The following is a description of a gene set: from publication Weber M, Hellmann I, Stadler MB, Ramos L, Pääbo S, Rebhan M, Schübeler D (PMID 17334365) Human Gene Set: WEBER_METHYLATED_ICP_IN_SPERM_UP Methylated germline-specific genes with intermediate-CpG-density promoters (ICP) in sperm. studied in species Homo sapiens To gain insight into the function of DNA methylation at cis-regulatory regions and its impact on gene expression, we measured methylation, RNA polymerase occupancy and histone modifications at 16,000 promoters in primary human somatic and germline cells. We find CpG-poor promoters hypermethylated in somatic cells, which does not preclude their activity. This methylation is present in male gametes and results in evolutionary loss of CpG dinucleotides, as measured by divergence between humans and primates. In contrast, strong CpG island promoters are mostly unmethylated, even when inactive. Weak CpG island promoters are distinct, as they are preferential targets for de novo methylation in somatic cells. Notably, most germline-specific genes are methylated in somatic cells, suggesting additional functional selection. These results show that promoter sequence and gene function are major predictors of promoter methylation states. Moreover, we observe that inactive unmethylated CpG island promoters show elevated levels of dimethylation of Lys4 of histone H3, suggesting that this chromatin mark may protect DNA from methylation., and this is the list of marker genes: POTEA, ACTL7B, TSSK2, PRM2, TDRD1 (NCBI Gene Id 56165), ANKRD7, PRSS21, CTCFL